The following is a description of a gene set: Human Gene Set: GOBP_FUSED_ANTRUM_STAGE studied in species Homo sapiens The stage in oogenesis when the antral spaces fuse to form a single antral space. The oocyte is suspended in the cumulus oophorous and the first polar body in the perivitelline space., and this is the list of marker genes: PTX3, NPPC (NCBI Gene Id 4880), BMPR1B, TNFAIP6, NPR2, EREG